Given this list of marker genes PAK2, CDKN1A, CTNNA1, VIM, NQO1, IER3, MAPK1, PTK2, ABL1, TNFRSF10B, GCLC, APOE, BEX3, VAV3, IL7R, HSPA5, AKT1, NFKB1, SQSTM1, CARD14, HSPB1, RPS6KB1, THBS1, ETS1, PTK2B, CUL1, TNF, CASP7, NRG1, HELLS, PKN1, JUND, TRAF1, SOCS3, CDKN1B, F2R, HDAC1, APP, BCL3, YBX3, AXIN1, RNF7, RIPK2, ERN1, CUL5, HSPD1, SMAD7, ERBB3, ANXA5, BIRC5, TNFRSF21, NET1 (neuroepithelial cell transforming 1), SERBP1, here is a description of the gene set: Human Gene Set: WP_APOPTOSISRELATED_NETWORK_DUE_TO_ALTERED_NOTCH3_IN_OVARIAN_CANCER Apoptosis-related network due to altered Notch3 in ovarian cancer species: Homo sapiens